Given this list of marker genes Gtf2a2, Kat7, Med23, Wbp2, Taf7l, Med17, Smarcd1, Phf2, Apex1, Dr1, Nfkbia, Med22, Taf3, Zfp451, L3mbtl3, Pabpc1l, 4930480E11Rik, Gtf2b, Wnt10b, Psmc6, Atf2, Gtf2e2, Nfkb1, Polr2g, Med15, Med13, Taf12, Ash2l, Tet3, Taf2, Sphk2, Egr1, Tet1, Apobec2, Ctcfl, Tsix, Smarcb1, Paxip1, Ercc6, Taf6, Ctnnbip1, Gtf2e1, Setd1a, Med10, Taf7, Pwwp2a, Cdk7, Hnf1b, N6amt1, Med21, Hnf1a, Taf4b, Ftx, Taf4, Med16, Znhit1 (NCBI Gene Id 70103), Pou5f1, Taf8, Gtf2f1, Ercc3, Med30, Apobec1, Srf, Med25, Mir744, Gtf2a1l, Taf10, Lcor, Kat8, Xpa, Med31 (mediator complex subunit 31), Macroh2a1, Trmt112, Sgf29, Med19, Taf5, Kdm2a, Aicda, Vps72, Gtf2h5, Samd1, Ercc2, Med4, Taf1, Wdr5, Trp53, Zfp473, Atad2, Med18, Med28 (NCBI Gene Id 66999), Men1, Med11, Med9, Spi1, Hey2 (NCBI Gene Id 30802), Kdm1a, Rbm14, Creb1, Brd7, Dhx36, Taf13, Myc, Ahr, Mnat1, Polr2i, Elob, Glyr1 (NCBI Gene Id 74022), Eloa, Taf11, Atad2b, Gtf2h1, Smarca4 (SWI/SNF related, matrix associated, actin dependent regulator of chromatin, subfamily a, member 4), Gtf2f2, Cand1, Fam47c, Med12, Zmpste24, Padi2, Tbp, Hmgb1, Maz, Eloc, Ikzf1, Kmt2a, Sirt7, Foxo1, Usp21, Ep300, Thra, 4930402K13Rik, Fam47e, Med26, Rbbp5, Taf9, Med29, Med6, Kdm1b, Bmyc, Sub1, Med1, Nr3c1, Nkx2-5 (NCBI Gene Id 18091), Letmd1, Taf6l, Polr2d, Ccnh (NCBI Gene Id 66671), Med8, Myocd, Dpy30 (dpy-30, histone methyltransferase complex regulatory subunit), Med24, Med20, Med27, Gtf2a1, Med7, Med14, Esr1, Tet2, Ogg1, Ercc1, here is a description of the gene set: A transcription initiation process that takes place at a RNA polymerase II gene promoter. Messenger RNAs (mRNA) genes, as well as some non-coding RNAs, are transcribed by RNA polymerase II. species: Mus musculus Mouse Gene Set: GOBP_TRANSCRIPTION_INITIATION_AT_RNA_POLYMERASE_II_PROMOTER